The following is a description of a gene set: species: Homo sapiens Human Gene Set: HP_ABNORMAL_AORTIC_VALVE_PHYSIOLOGY Abnormal aortic valve physiology, and this is the list of marker genes: GATA4, KLRC4, PUF60, NEK8, ADA2, ERMARD, MYLK, ODAD1 (outer dynein arm docking complex subunit 1), ABCC6, D2HGDH, HLA-B, STAT4, MAT2A, YY1AP1, B4GALT7, HEATR3, CHST3, TMTC3, IL23R, AMER1, ADAMTS19, RIGI, NR2F2 (nuclear receptor subfamily 2 group F member 2), KDM6A, TRIP13, DOCK7, EIF4H, ROBO4, KMT2D, DPH2, STX1A, ARFGEF2, TBL2, TGFBR1 (transforming growth factor beta receptor 1), MAP1B, RMRP, UBAC2, LTBP2, GNPTAB, TGFB2, IL12A-AS1, IFT56, PLXND1, TGFB3 (NCBI Gene Id 7043), IFNGR1, DPH1, SLC2A10, WASHC5, SMAD2, SKIC3, TGFBR2, DOHH, CREBBP, MFAP5, NOTCH2, FOXE3, PCGF2, FBN1, ENPP1, RFC2, DYRK1A (NCBI Gene Id 1859), FBLN5, BAZ1B, CLIP2, GJA5, MYH11, LDLR, KRAS, GATA5, NOTCH1, BCR, IL12B, ACTB (actin beta), IDUA, NEDD4L, ARSK, ZMPSTE24, BCOR, LIMK1, GBA1 (NCBI Gene Id 82008), PEX2, MLXIPL (MLX interacting protein like), CBL, TAB2, ARHGAP31, FKBP6, ADAMTS10, EFEMP2, PRKG1, APOB, LOX, CCDC22, ABCG8, LDLRAP1, NCF1 (neutrophil cytosolic factor 1), IFIH1, NKX2-5, MAN2B1, CCR1, CRKL, NKX2-6, COA6, SON, WT1, SPTBN1, ELN, METTL27, FOXF1, ERAP1, IL10, BUD23, HCN4, SNIP1, CLIC2, FLI1, CEP57, SPRED2, KIFBP, ADAMTSL2, COL1A2 (collagen type I alpha 2 chain), LMNA, MEFV, GTF2IRD1, FGFR1, IL12A, ZEB2, DNAJC30, EBP, LMOD2, ARF1, HEY2, CHST14, TBX1, TRAF7, VWF, NPHP3, CCNQ, ATP6V1E1, ACTA2, GLB1 (NCBI Gene Id 2720), BUB3, GJA8, SZT2, SKIC2, TMEM270, PCSK9, EP300, ANKS6, C12orf57, ALDH18A1, GTF2IRD2, SCN1B, HAAO, EHMT1, FLNA, SMAD6, VPS35L, TAF2, VPS37D, TTR, SMAD4, ABCG5, LTBP1, SHOC2, RRAS2, TWIST1, SLC35A1, ADAMTS17, GNPTG, TLR4, BUB1B, BUB1, MLX, C4A, FAS, GTF2I, HGD, MAPK1, DPYSL5, SMAD3, THSD4, PDSS1